Given this list of marker genes PSMC1, PSMC4, ACTG1, PSMB3, EPS15, JUP, PSMD3, PSMB1, PSMB2, ACTC1 (NCBI Gene Id 70), ADRM1, PSMB4, CDH1, PSMD11, VCL, PSMD12, BANP, SEM1, UCA1, CTNNB1, PSMD14, PSMA7, RPS27A, PSMB5, UBA52, MTBP, PSMD13 (NCBI Gene Id 5719), PSMD8, SRC, CBLL1, UBB, PSMA2, CTSB, PSMA6, CTNNA1, ACTA1, PSMA5, PSMC6, PSMD6, FYN, PSMD1, DNM2 (dynamin 2), PSMB7, CTNND1, PSMA3, PSMC2, UBC, MDM2, PSMD7, CTSS (cathepsin S), PSMC3, PSMA4, CTSL, PSMA1, ACTA2, PSMD2, ACTG2, PSMB6, RACK1 (receptor for activated C kinase 1), ACTB, PSMC5, here is a description of the gene set: studied in species Homo sapiens part of: Regulation of CDH1 Expression and Function Reactome Pathway: Regulation of CDH1 Function To function in formation of adherens junctions, CDH1 (E-cadherin) has to associate with catenin proteins at the plasma membrane. Beta-catenin (CTNNB1) and gamma-catenin (JUP, also known as plakoglobin) compete for the same binding spot on CDH1 C-terminus. In addition, delta-catenin (CTNND1, also known as p120 or CAS) also binds the C-terminus of CDH1. Alpha-catenin (CTNNA1) associates with CDH1 indirectly, through CTNNB1 or JUP. For establishment of adherens junctions between neighboring cells, CDH1 has to form an antiparallel complex that consists of two CDH1:catenin complexes from two opposing cells, arranged in an antiparallel fashion. Formation of an antiparallel complex requires the presence of CTNND1 in the CDH1:catenin complex and the presence of extracellular calcium. Two CDH1 molecules from the same cell join in a parallel fashion to form a lateral CDH1 complex through dimerization of the N-terminal extracellular domains of CDH1. Formation of the lateral complex does not require the presence of calcium or CTNND1. Binding of CTNNB1 or JUP is critical for CDH1 stability and cell surface localization. In the absence of CTNNB1 or JUP binding, CDH1 is targeted to lysosomes for degradation. Overexpression of CTNND1 can partially rescue CDH1 from degradation in the absence of CTNNB1/JUP binding.<br><br>Although CTNND1 does not recruit CTNNA1 to the CDH1:catenin complex, it may engage in intra-complex interactions with CTNNA1.